Given this list of marker genes Srf, Mir19a, Dag1, Igfbp5, Tab1, Pdgfa, Sp1, Mapk8ip3, Dspp, Ncor2, Msc, Hopx, Bag6, Tgfb3, Nphp3, Hps1, Ywhaz, Disp1, Dhcr7, Tbx2, Cebpa (NCBI Gene Id 12606), Hhip (Hedgehog-interacting protein), Wnt5a, Rarg, Bmpr2 (bone morphogenetic protein receptor type 2), Tnc, Dnaaf1, Nog, Vegfa, Phf14, Agr2, Aldh1a2, Mgp, Gli1, Hoxa5, Man1a2, Clcn2, Ppp1ca, Mir302d, Itga3, Eva1a, Gng8, Itgb6, Gata4, Col6a1, Wnt7b, Nfib, Hipk2, Grhl2, Scnn1b, Tbx5, Mme, Spry1, Crispld2, Mosmo, Mir18, Dicer1, Fgf10, Gh, Rpgrip1l, Phex, Cdc42, Tmem38b, Ano1, Yap1, Col3a1, Six4, Mir19b-1, Lhx3, Zfp157, Pdgfrb, Gli3, Msx1, Myocd, Myt1, Slc23a1, Fgfr1, Fosl2, Adamts2, Rspo2, Foxf1, Pou2f1, Foxp4, Rpl13a, Smad2, Asah1, Fgfrl1 (NCBI Gene Id 116701), Smpd3, Foxa2, Ctsl, Adamtsl2, Asxl1, Hikeshi, Sp3, Vangl2, Fgf9, Tmtc3, Gpc3, Klf2, Aldh1a3, Rbp4, Zic3, Thrb, Ptges3, Lta4h, Lrp6, Esrp1, Meg3, Hmga2, Cyp1a2, Speg, Stra6, Kdr, Spdef, Nodal, Wdpcp, Edaradd, Chd7, Lipa, Hsd11b1, Bloc1s6, Phox2b, Fndc3b, Fkrp, Ccdc40, Flt4, Lama5, Elk1, Wnt11, Igf1, Pthlh, Rdh10, Ada, Atxn1, Mir17, Pdpn, Prox1, Ppp3r1, Pkdcc, Sftpd, Tbx4, Tshz3, Dnaaf3, Mir302c, Foxa1, Hesx1, Mapk3, Aimp2, Mycn, Nkx2-9, Sav1, Hydin (NCBI Gene Id 76711), Timeless, Fgf18, Abca12 (ATP-binding cassette, sub-family A member 12), Hmga1, Sox2, Lif, Zfpm2, Mnx1, Spry2, Thra, Atxn1l, Pkd1, Celsr1, Sparc, Mapk1, Nkiras1, Flvcr2, Nkiras2, Lef1, Nos3, Selenon, Sox11, Rxfp1, Fgf1, Dlg5, Hmgcs2, Foxp2, Dppa2, Ctnnb1, Ctsz, Ift25, Srebf1, Fbxw7, Cfc1, Fuz, Cldn18, Rbpj, Psen2, Fgf2, Creb1, Cux1, Nkx2-1, Eda, Foxp1, Ptk7, Ep300, Map2k1, Id1, Fgf8, Lama1, Tgfbr2, Trp73, Wnt2b, Odad4, Hs6st1, Ascl1, Map2k2, Gstcd, Hmgb1, Egfr, Hes1, Pgr, Fgfr4, Rab3a (NCBI Gene Id 19339), Man2a1, Rbbp9, Tns3, Ext1, Ski, Tcf21, Tgfb1, Ap3b1, Errfi1, Gli2, Ctsd, Lox (NCBI Gene Id 16948), Fgfr2, Rc3h2, Ctsh, Ift88, Heg1, Anxa2, Mecp2, Fbn1, Chi3l1, Stk40, Mir92-1, Hhex, Wwp1, Srsf6, Bmp4, Wt1, Kras, Ccbe1, Plod3, Pitx2, Sfta3-ps (surfactant associated 3, pseudogene, NCBI Gene Id 104798), Mir302b, Bmp2, Smchd1, Eif4g1, Cftr, Ccdc39, Mir367, Bmpr1a, Cic, Foxj1, Spef2, Ltbp3, Notch1, Jmjd6, Tnrc6c, Shh, Fendrr, Sim2, Muc19, Fgf7, Ccn2, Dlx5, Edn2, Epas1, Abca3, Six1 (sine oculis-related homeobox 1), Slc7a11, Atp7a, Rara, Mmp14, Dppa4, Sec24b, Esrp2, Rcn3, Ass1, Pdgfra, Gata6, Tmem67, Acvr2b, Sox9 (SRY (sex determining region Y)-box 9), Ace, Tulp3, Mir302a, Loxl3, Mmp12, Crh, Fgfr3, Wnt2, Mir20a, Tnf, here is a description of the gene set: Mouse Gene Set: GOBP_RESPIRATORY_SYSTEM_DEVELOPMENT The progression of the respiratory system over time from its formation to its mature structure. The respiratory system carries out respiratory gaseous exchange. studied in species Mus musculus